Given this list of marker genes PAICS, PFAS, PPAT, ADSL, ATIC, GART, here is a description of the gene set: The chemical reactions and pathways resulting in the formation of IMP, inosine monophosphate, by the stepwise assembly of a purine ring on ribose 5-phosphate. Human Gene Set: GOBP_DE_NOVO_IMP_BIOSYNTHETIC_PROCESS studied in species Homo sapiens